The following is a description of a gene set: Human Gene Set: GOBP_POSITIVE_REGULATION_OF_RESPIRATORY_BURST species: Homo sapiens Any process that increases the rate frequency or extent of a phase of elevated metabolic activity, during which oxygen consumption increases; this leads to the production, by an NADH dependent system, of hydrogen peroxide (H2O2), superoxide anions and hydroxyl radicals., and this is the list of marker genes: LBP, IGHA1, CAMK1D, JCHAIN, RPS19, IGHA2, INS, INSR, CLEC7A